The following is a description of a gene set: The process whose specific outcome is the progression of a gland over time, from its formation to the mature structure. A gland is an organ specialised for secretion. studied in species Mus musculus Mouse Gene Set: GOBP_GLAND_DEVELOPMENT, and this is the list of marker genes: Aco2, Mafb, Psap, Stat6, Igf1, Pinc, Ceacam1, Scd1, Smarca4, Cav1, Bax, Rarg, Aprt, Tfcp2l1, Prl7d1, Ucp2 (uncoupling protein 2 (mitochondrial, proton carrier)), Prl8a2, Prox1, Asl, Rara, Hnf1b, Mrtfb, Cdkn1b, Npc1 (NCBI Gene Id 98121), Sco1, Runx1, Hif1a, Phb2, Chaserr, Prl7c1, Pml, Pax1, Tgm2, Asns, Msx1, Eif2ak3, Aldh1a2, Oas2, Hrh2, Foxn1, Nf1, Smad2, Elk1, Chuk, Lats1, Lama5, Dag1, Cyp1b1, Hhex, Ghrh, Ccdc40, Hoxa3, Lims1, Esrp1, Nkx2-1, Wnt11, Stk11, Crkl, Prl7a2, Serpinf1, Fgf1, Lrp5, Duox2, Prl2c3, Cited2, Ggt1, Fkbp4, Zbtb7b, Tfap2c, Ugt1a1 (NCBI Gene Id 394436), Cdk5rap3, Jarid2, Hoxb9, Mdk, Wnt3, Raf1, Psapl1, Kalrn, Slc12a2, Sulf2, Ddr1, Polb, Ptch1, Robo1, Pkd2, Irf6, Msn, Msx2, Pthlh, Stra6, Rxfp1, Pdx1, Aurka, Gli3, Sp1, Lsr, Six4, Slc29a1, Ash1l, Zfp157, Esr2, Etv4, Cebpg, Hnf1a, Igf1r, Inhbb, Rps6ka1, Sostdc1, Sp3, Slc46a2, Ctnnd1, Proc, Tgfa, Il18, Med1, Prkdc, Cckbr, Clcn2 (NCBI Gene Id 404589), Areg, Ldha, Lims2, Vwf, Slc6a3, Man2a1, Nr0b1, Hpcal1, Foxc1, Ptf1a, Serpina10, Zbtb1, Fpgs, Prl, Otp, Taf10, Fgf10, Hmbs, Apc, Prl6a1, Tgfbr2, Cps1, Nog, Foxm1, Slc7a5, Hnrnpd, Vdr, Hmga2, Pax8, Gpat4 (NCBI Gene Id 55933), Ppdpf, Nkx2-3 (NK2 homeobox 3), Ptcd2, Eaf2, Ext1, Hoxa10, Apoa1, Cd44, Foxh1, Ugt1a8, Fgl1, Nr3c1, Fgf3, Kdm1a, Cdkn2a, Prl2c5, Ncoa1, Itpr1, Cdkn2b, Hesx1, Hes1, Hipk2, Prl2c2, Srp54a, Tbx2, Hoxd3, Hoxa11, Cflar, Gpx1, Foxa1, Srf, Aldh1a3, Prl2c1 (Prolactin family 2, subfamily c, member 1), Tgfb2, Map2k2, Bsx, Tph1, Acat1, Csmd1, Smad4, Insm1, Umps, Irs1, Iqgap3, Atg7, Rb1cc1, Mst1, Ednra, Rbpj, Cebpa, Pygo2, Atf7, Cela1, Prl3d2, Prop1, Gfer, Braf (NCBI Gene Id 97330), Atp2c2 (NCBI Gene Id 69047), Ephb3, Cdc42, Etv5, Ikzf1, Pnpt1, Csn3, Hmga1, Rcbtb2, Crh, Naglu, Tg, Ntn1, Insr, Upb1, Pik3ca, Sox2, Prl8a8, Hlx, Rag1, Arid5b, Slco1b2, Baat, Zdhhc21, Abl1 (NCBI Gene Id 98922), Adrm1, Atf2, Plaur, Arhgap5, Ar, Pax6, Cdh1, Tcf21, Cacnb4, Csf1, Vtn, Notch2, Prl3d3, Frs2, Tgfb3, Prl8a1, Nkx2-5, Epha2, Tbx1, Cadm1, Reg1, Cbx7, Hgf, Pitx1, Fgfr1, Tnc, Bcl2l11, Tgfbr3, Prdx2, Stat5a, Dut, Eda, Plag1, Ly6e, Prl5a1, Ift88, Prl4a1, Esrp2, Jak2 (NCBI Gene Id 98155), Drd2, Armc5, Serpina5, Neurl1a, Ascl3, Ifng, Hp, Smarcc1, Hnf4aos, Lhx3, Hoxb13, Muc19, Gdf7, Ghrhr (growth hormone releasing hormone receptor), Pck2, Pten, Pkm, Sema3a, Twsg1, Wls, Plxnd1, Tet2, E2f7, E2f8, Cldn1, Igfbp5, Ccl11, Ccnb2, Tnfrsf11a, Edar, Mapk1, Errfi1, Foxi3, Met, Fgf2, Serpine2 (serine (or cysteine) peptidase inhibitor, clade E, member 2), Tnf, Cdkn1c, Map2k1, Rreb1, Gata2 (NCBI Gene Id 14461), Sox9, Pitx2, Prl2b1, Zic3, Slit2, Pax3, Ptn, Sfrp1, Icmt, Ctns (NCBI Gene Id 83429), Notch1, Ptpn3, Mapk3, Pcsk1, Nr5a1, Crhr1 (NCBI Gene Id 12921), Six1, Elf5, Pcna, Ass1, Vegfa, Dkk3, Six3, Rpl10, Tubb1, Atp2b2, Ugt1a7c, Pcsk9, Bcl11b, Aire, Prl3b1, Mir30a, Isl1, Tspo, Nrg3, Igf2, Mki67, Gsx1, Foxe1, Rtn4, Mmp2, Tnfsf11, Cad, Hpn, Ntn4, Wdr77, Sox10, Asxl1, Cp, Rhbdd3, Trp63, Pdgfra, Gja1, Adcyap1, Shh, Rap1gap, Ccnd1, Abcb1a, Btbd7, Cpb2, Aacs, Wt1, Il10, Mad1l1, Gli1, Hoxa5, Hfe, Plxna1, Nfkb1, Foxa3, Lrp6, Acer1, Snai2, Cul3 (cullin 3), Tnfaip3, Wnt5a, Ncoa3, Prl2a1, Deaf1, Cyp7b1, Bmp7 (bone morphogenetic protein 7), Wnt3a, Nr5a2, Hoxa13, Nodal, Csn2, Gli2, Xdh, Id2, Il6, Lmo4, Irs2, Prkcsh, Klf1, Kdm5b, Sema3c (NCBI Gene Id 68696), Carmil2, Prl3d1, Nkx3-1, Hand2, Ada, Ahr, Smo, Cdo1, Hk2, Src, Elf3, Fem1b, Ihh, Acadm, Psen2, Cfc1, Brca2, Usf2, Pdgfa, Smad3, Otc, Upf2, Hoxb3, Krt76, Rgn, Rln1, Notch4, Cd2ap, Bmp2, Pgr, Psen1, Sox3, Cga, Zfp703, Tyr, Ctc1, Sod2, Cebpb, Pck1, Ube3a, Btrc, Creb1, Sec63, Cav3, Capn1, Cobl, Ugt1a9, Hmox1, Foxf1, Rplp0, Lbh, Gata3, Mpst, Id4, Sulf1, mt-Co2, Nfatc3, Myb, Ceacam2, Rpgrip1l, Tyms, Rela, Lama1, Hspa12a (heat shock protein 12A), Orai1 (ORAI calcium release-activated calcium modulator 1), Gata6, Ezh2, Edn1, Prl3c1, Hoxd9, Zmpste24, Nphp3, Fa2h, Wnt2, Thra, Bcl2 (NCBI Gene Id 98734), Fgfr2, Nherf1, Nme1, Bmp4, Dnaaf1, Prl8a9, Frzb, Fgf8, Ccl2, Ccdc39 (NCBI Gene Id 99728), Prl3a1 (prolactin family 3, subfamily a, member 1), Zfas1, Ascl1, Igf2r, Erbb4, Egf, Esr1, Perp, Ctnnb1, Fasn, Pou1f1, Agap2, Nrp1, Tgfb1, Mesp1, Fgf18, Tgfbr1, Serpinb5, Hoxa9, Socs2, Cpt1a, Pou3f2 (POU domain, class 3, transcription factor 2), Cyp19a1, Cyp1a1, Coa5, Itga2, Wnt10a, Prl7a1, Onecut1, Gsdma3, Gak, Csnk2a1, Arf6, Pbx1, Prl8a6, Hoxd13, Wnt1, Hmgcs2, Fadd, Nfib, Foxb1, Smarcb1, Ezh1, Tbx19, Pdgfrb, Gba1, Meg3, Gcm2, Xbp1, Arhgap35, Lipa, Onecut2, Tcf7l2, Plau, Wnt4 (NCBI Gene Id 22417), Tbx3, Ripk3, Egfr, Scrib, Stat5b, Atp7b, Fgf7, Atm, Igsf3, Lef1, Prl7b1, Jun, Rxra, Uprt, Prlr, Pkd1, Bmpr1a, Pdgfb, Edaradd